Given this list of marker genes PDE7A, MYL6, HOXA1, STON2, NCAM2, CPNE1, PRG4 (proteoglycan 4), ZFPM2, HTN1, GLYR1, RHOG, GLIS3, SLC7A3, PDS5A, SLC25A14, ENOX1, SRPK2, SCUBE3 (signal peptide, CUB domain and EGF like domain containing 3), IL7, AMMECR1L, ASIC2, MPDU1, ZFPM1, NHLH2, NDST2, MAP4K5, CYRIA, BCL6, DCAF11, RSKR, LPAR4, MBNL2, RSPO2, SOX11, S100A16, HS3ST5, TMEM47, ADNP, CREB5, CAPNS2, CNP, WDR82, DSG1, FBH1, HOXD10, SLC37A4, PHEX, UBXN10, RASD1, HOXC12, NRAS, NRP1, SLC9A9, NKD1, TSHB, GAD1, PPARGC1A, DMD, NCBP3 (NCBI Gene Id 55421), GCG, HTR3B, ASB2, SEPTIN9, LRR1, CASQ2 (NCBI Gene Id 845), TENT5A, FAM91A1, PTGDR2, OTX2, TOR1AIP2, RBM47, RAB11FIP1, RASGRF2, PKLR, SUDS3, NKX2-1, PLAG1, LONRF3, IKZF2, VAMP1, PTGFR, VASN, SLITRK2, LIX1, KYNU, PTPRC, DIDO1, HIPK1, MSX2, OR13C3, CRAT, CHCHD7, ZNF76, SPATA31H1, CIMAP3, TOB1, ESRRG, CEP20, PROX1 (NCBI Gene Id 5629), MYCT1 (NCBI Gene Id 80177), EWSAT1, KCNJ13, IL4, MTMR10, RAI1, RBM39, SPINK4, LRRN1, ISL1, LRRC8A, BICDL1, UBE2K, HSPB3, H3-3A, TUG1, ARK2N, LMO2, BCL11B, CTNNA3, SYNCRIP, FHL3, KLF14, ABCB7, BMP10, ARPC2, ADPRHL1, TTC29, EVX1, KCNJ16, ADAMTS3, LINC03122, SIX1, KCNMB2, RUNX1T1, PAX2, SHISA6, ENTR1, here is a description of the gene set: studied in species Homo sapiens Genes having at least one occurrence of the motif AGAYAAGATAA in the regions spanning 4 kb centered on their transcription starting sites. This matches the EVI1 transcription factor binding site V$EVI1_02 (v7.4 TRANSFAC). Human Gene Set: EVI1_02